The following is a description of a gene set: Human Gene Set: GSE39152_BRAIN_VS_SPLEEN_CD103_NEG_MEMORY_CD8_TCELL_UP from publication Wakim LM, Woodward-Davis A, Liu R, Hu Y, Villadangos J, Smyth G, Bevan MJ (PMID 22922816) Tissue resident memory (Trm) represent a newly described memory T cell population. We have previously characterized a population of Trm that persists within the brain following acute virus infection. Although capable of providing marked protection against a subsequent local challenge, brain Trm do not undergo recall expansion following dissociation from the tissue. Furthermore, these Trm do not depend on the same survival factors as the circulating memory T cell pool as assessed either in vivo or in vitro. To gain greater insight into this population of cells we compared the gene-expression profiles of Trm isolated from the brain to circulating memory T cells isolated from the spleen following an acute virus infection. Trm displayed altered expression of genes involved in chemotaxis, expressed a distinct set of transcription factors and overexpressed several inhibitory receptors. Cumulatively, these data indicates that Trm are a distinct memory T cell population disconnected from the circulating memory T cell pool and displaying a unique molecular signature which likely results in optimal survival and function within their local environment. Genes up-regulated in memory CD8 T cells, ITGAE- population: brain versus spleen sources. species: Homo sapiens, and this is the list of marker genes: CSF1, BAG1, RAD17, HSP90AB1, SAP30, BLTP3A, MBNL1, MAP4K3, ARPC2, ODC1, PLEC, ADK, RAP1GDS1, SNX10, USP18, TTC27, DAP3, FAS, TANK, MARCHF5, HIVEP1 (NCBI Gene Id 3096), GBP7, E2F8, IRF9, LRPPRC, ZNF281, TINAGL1, ACADL, SNX12, SLC6A12, MAX, RELL1 (RELT like 1), GKAP1, LPL, SPRED2, BTG3, FMR1, ATF1, MDM2, ANKRD13C, SUN2, CCT5, BCL2L1, TUBB2A, BCL6, AZI2, ATAD3A, MINPP1, KLF2, DAG1, RNF34, PDHB (pyruvate dehydrogenase E1 subunit beta), NAV2, NAMPT, ACOD1, DEGS1, IGF1, AP1AR, STMN1, TSNAX, CD164, RTN4, RARS1, SLC39A6, PLA2G4A, OTUD4, ADSS1 (adenylosuccinate synthase 1), NOC4L, EMP1, DNAJA2, HLA-B (major histocompatibility complex, class I, B), ZNHIT3, SQSTM1, IRGM, OAS1, CWC15, ACTG1, RASA4, DCK, SLC25A28 (NCBI Gene Id 81894), DSTN, PTPN2, DOK2, PDK3, TTR, MBD2, TEC, ANXA4, LASP1, TCP1, ATP6AP2, FABP3, LSP1, ISOC1 (NCBI Gene Id 51015), HPRT1, CENPV, NVL, BCL2A1, NDUFA2, THUMPD1, FXN, TBCA, CD83, HDAC2, RACK1, ACYP2, RALA, FNBP4, IL15, DRG1, PLAA, EEA1, TOR1AIP2, PPP1R15B, ATP13A3, FARS2 (NCBI Gene Id 10667), MMP13, CLIC4, NCR1, IQGAP1, UBL3, DPPA5, TAP1, ZNF398, VCL, TRIM27, M6PR, CLK4, PRKD3, PSMD6, FYN, QDPR, BRIX1, ATP1B3, HNRNPK, USO1, GCH1, CTBP1, RBM3, SH3BGRL, CHUK, RFC3, PEBP1, CDK8, RNASEH1, CAVIN1, KIT, ANKH, PLAC9, RNF19B, ETFB, ATF3, PFKP, JAK2, KLHL7, H3-5, PLXND1, ACTN4, RFC2, LGALSL, CDH5, AGFG1, PLPP1, CHTOP, TXNRD1, IKBKG, PTGS2, LYRM2, SF3A3, ANKRD17, GBP4, TRAF1, CYP2C19, FAM120A, ZFPM1, PSMB4, HNRNPA1, KALRN (NCBI Gene Id 8997), SGCA, EIF5, KITLG, LPCAT1 (NCBI Gene Id 79888), MT2A, RBMS1, FGFR1OP2, ZNF639 (NCBI Gene Id 51193), CXCL10, CASP3 (NCBI Gene Id 836), RUFY1, PAXBP1, U2SURP, STAT1, NONO, MTDH, NRAS, CAPN2, EML5, PLSCR1, GPX3, IFI35